Given this list of marker genes NPPB, INPP5K, AKR1B1, NPR1, EDNRB, ADORA2A, HYAL2, ADM, UMOD, NPR3, HAS2, OXT, DRD2 (NCBI Gene Id 91906), SLC4A1, TRPV5, ADCY6, GNAI2, BTC, AVPR2, EDN1, MLLT6, here is a description of the gene set: Human Gene Set: GOBP_REGULATION_OF_URINE_VOLUME Any process that modulates the amount of urine excreted from the body over a unit of time. studied in species Homo sapiens